Given this list of marker genes Vav1, Gstm6, Xdh, Nudt15, Gsta1, Tpmt, Nme2, Gsta3, Guk1, Abcc4, Gsta2, Gsta13, Nme1 (NCBI Gene Id 18102), Impdh2, Gmps, Slc29a2 (solute carrier family 29 (nucleoside transporters), member 2), here is a description of the gene set: Reactome Pathway: Azathioprine ADME species: Mus musculus This event has been computationally inferred from an event that has been demonstrated in another species.<p>The inference is based on the homology mapping from PANTHER. Briefly, reactions for which all involved PhysicalEntities (in input, output and catalyst) have a mapped orthologue/paralogue (for complexes at least 75% of components must have a mapping) are inferred to the other species. electronically inferred by orthology from the curated human pathway part of: Drug ADME